Given this list of marker genes Foxo1, Pon1, Col1a1, Aspn, Atg5, Plcb1 (phospholipase C, beta 1), here is a description of the gene set: studied in species Mus musculus Any process that results in a change in state or activity of a cell or an organism (in terms of movement, secretion, enzyme production, gene expression, etc.) as a result of a fluoride stimulus. Mouse Gene Set: GOBP_RESPONSE_TO_FLUORIDE